The following is a description of a gene set: Human Gene Set: REACTOME_TRANSCRIPTIONAL_REGULATION_OF_GRANULOPOIESIS Transcriptional regulation of granulopoiesis studied in species Homo sapiens, and this is the list of marker genes: H4C1, RUNX1, CDK2, H2AC7, H3C1, H2BC14, TAL1, H2AZ2, H4C5, CSF3R, H2BC5, CEBPE, H3C7, CBFB, KLF5, H2AB1, H3C8, H2BC13, H4C4, CREB1, H2BC10, H3C2, H3C15, H2AC20, H2BC7, TFDP1, H4C12, H4C14, PML, H3C10, H3C4, H4C2, CDKN1A, H2BC15, H4C9, H2AJ, MYB, H2BC26, H2BC8, H4C8 (H4 clustered histone 8), H2AC18, H4C15, H2BC4, H3C12, H3C6, EP300, H2AX, H2BC1, E2F1, CEBPB, GATA2, H2AC6, STAT3, H2BC9, RARA, H3-3B, LEF1, DEK (DEK proto-oncogene), H2BC17 (NCBI Gene Id 8348), CDK4, H2AC8, H2BC21, CEBPA, GFI1, H3-3A, H2AC14, TFDP2, H4C6, H4C11 (NCBI Gene Id 8363), H2AC4, H2BC12, H2BC3, KMT2A, H4C16, MYC, H2BC12L, H3C14, H2BC11 (H2B clustered histone 11), H4C13, H2AC19, H3C13, RXRA, H4C3, H3C3, SPI1, H2BC6, IL6R, FLI1, H3C11